The following is a description of a gene set: Human Gene Set: MODULE_29 Genes in the cancer module 29. studied in species Homo sapiens, and this is the list of marker genes: RPS18 (NCBI Gene Id 6222), DAP3, RPS27, RPS13, RPS6, RPSA, RPS25, RPS2, RPS26, RPS16, RPS10, RPS4X, RPS29, RPS23, RPS7, RPS20, RPS8, RPS17, RPS12, RPS21, RPS4Y1, RPS15A, RPS24, RPS3, RPS28, RPS14, RPS15, RPS19